Given this list of marker genes KIF20B, PRC1, CENPE, KIF18B, CTTN, MAP9 (NCBI Gene Id 79884), RCC2, MAP10, AURKB, NUMA1 (nuclear mitotic apparatus protein 1), HNRNPU, KIF18A, OR2A4, EML1, here is a description of the gene set: studied in species Homo sapiens The area in the center of the anaphase spindle consisting of microtubules, microtubule bundling factors and kinesin motors where the spindle microtubules from opposite poles overlap in an antiparallel manner. Human Gene Set: GOCC_MITOTIC_SPINDLE_MIDZONE